The following is a description of a gene set: Any process that modulates the frequency, rate or extent of hydrolase activity, the catalysis of the hydrolysis of various bonds, e.g. C-O, C-N, C-C, phosphoric anhydride bonds, etc. Hydrolase is the systematic name for any enzyme of EC class 3. species: Mus musculus Mouse Gene Set: GOBP_REGULATION_OF_HYDROLASE_ACTIVITY, and this is the list of marker genes: Ric1, Tbc1d20, Pla2r1, Cast, Serpinb1b, Cav2, Cstb, Ralgapb, Chp1 (calcineurin-like EF hand protein 1), Mtmr9, Rgs10, Oas1f, Epha2, Rab3gap1, Ccdc159, Ecm1, Csta1, Cldn4, Timp3 (NCBI Gene Id 268324), Npnt, Nos1, Rdx, Oas1h, Csta2, Uri1, Spock1, Spink2, Sh3bp1, Furin, Rgs2, Serpinb13, Smcr8, Bmp2, Apoa5, Ect2, Scrib, Stfa2, Nf1, Gapdh-ps15, Cstdc6, Cstdc4, Rack1, Ifng, Apoc1, Cstdc3, Ptk2b, Amot, Pycard, Lrch1, Wnt4, Epha5, Srgap2, Calm1, Tmed10, Rasgrf1, Camk2a, Mtor, Psma3, Arfgef1, Cxcl13, Sgsm3, Rasgrp3, Rgp1, Nr1h2, Rhoa, Serpine1, Serpinb6e, Vav1 (vav 1 oncogene), Ubxn1, Ang4, Apoa1, Rangap1, Spink5, Tank, Rgs14 (regulator of G-protein signaling 14), Apoa2, Ppargc1b, Serpinb9c, Itgb1bp1, Fgfr3, Ppp1r17, Epha4, Spink6, Sod1, Serpinb9f, Apc2, Sipa1l1, Nos3, Hras, Serpinb1a, Mtss2, Akt1 (thymoma viral proto-oncogene 1), Pde3a, Ndel1 (nudE neurodevelopment protein 1 like 1), Ccpg1, Apoc3, Oas1a, Eppin, Vcp, Tmem106b (NCBI Gene Id 76086), Oas1e, Wnk1, Fermt2, Ccr7, Ager, Svbp, Mlst8, Arhgap35, Gpr137b, F2r, Arhgap11a, Timp1 (tissue inhibitor of metalloproteinase 1), Adap1, Dock8, Ang6, Arhgef19, Rasgrp2, Dab2ip, Rapgef1, Rgs16, Wdr41, Efna5, Met, Dennd1b (DENN domain containing 1B), Grhl3, Gapdh, S100a10, Ralbp1 (NCBI Gene Id 268968), Kalrn, Arhgef10, Usp6nl, Spink1, Arhgap44, Syde1, Gpr65, Asap3, Crkl, Serpinb9h, Cdk5rap3, Fetub, Wnt5a, Calm2, Spry1, Serpinb6d, Avpr1b, Rictor, Serpinb6b, Pnlip, Dock11, Pla2g5, Slc27a4, Nedd9, Scarb2, Arap1, Sort1, Stat3, Tbc1d2, Antxr1, Psenen, Grn, Calm3, Akt2 (thymoma viral proto-oncogene 2), Rabgap1, Prkcd, Angptl4, Csta3, Gpld1, Agrn, Dock9, Sgsm2, Tbc1d7, Prex1, Plxnb2 (NCBI Gene Id 73840), Rrp1b, Rgs6, Gpihbp1, Rgma, Timp2, Ngef, Rsu1, Chp2, Abr, Map4k4, Rab3gap2, Gnb5, Usp17le, Pkp4, Dvl2, Tax1bp3, Prelid1, Stmn1, Apoa4, Rgs1, Prom2, Dgki, Angptl3, Bbs4, Prss22, Ptx3, Ralgapa2, Snx9, Apoc2l, Lars1, Ntf3, Bcar3, Ajuba, Prtn3, Tmed2, Arhgap42 (NCBI Gene Id 71544), Mapre2, Gapdhrt2, Serpinb9g, Epm2a, Snx18, Mmut, Tiam1, Rhoc, Terf1 (telomeric repeat binding factor 1, NCBI Gene Id 21749), Rapgef6, Apcs, Psmb8, Itgb1, Mef2c, Nr1h3, Lrp1, Snca, Gapdhrt, Dock10, Pot1b, Ctsh, Wrn, Spock3, Cstdc5, Mkks, Plxnb1, Arl2, Ang2 (angiogenin, ribonuclease A family, member 2), Ccdc125, Arhgap6, Bcl6, Tbc1d10b, Mbp, Cd200, Coro1c, Rapgef2, Sirt1, Efna3, Tgm2, Rhbdf2, Plin5, Ttc8, Arhgap1, Lmf1, Evi5l, Terf2, Oas1c, Atp13a2, Zc3h15, Stfa1, Apoh (NCBI Gene Id 11818), Ripk3, Arhgef16, Pafah1b1, Rtn4r (reticulon 4 receptor), Ntrk2 (neurotrophic tyrosine kinase, receptor, type 2), Serpinb9e, Ccn1, Cst7, Ang5, Agtr1b, Reck, Ezh2, Rgs8, Rps3, Crb2, Ccl24, Serpinb9, Serpinb8 (NCBI Gene Id 20725), Ang, Rapgef3 (NCBI Gene Id 70104), Thy1, Plxnb3, Ncstn, Arhgef5, Ccl11, Pin1rt1, Prkg1, Vav3, Lims1, Ralgapa1, Serpine2, Nrdc, Bcr, Dvl3, Ntrk3, Fgfr2, Epha3 (Eph receptor A3), Pin1, Rcn3, Arhgap24, Gpsm1, Tbc1d30, Gzma, Cst3, Vav2, Pip5k1a, Evi5, Lepr, Aph1c, Dennd1a, Adcyap1, Tns3, Serpinb9b, Neil1, Sema4d, Odam, Tsc1, Rasip1, Rap1gap, Rhog, Serpinb1c, Cav1, Myo9b, Aph1a, Ccl19, Snx13, Oas3, Mex3b, Apoc2, Npm1, Net1, Arhgef7, Wnt11, Rap1a (NCBI Gene Id 99734), Oas1b, Cldn3, Tnf, Oas1d (2'-5' oligoadenylate synthetase 1D), Bves, Serpinb6a (serine (or cysteine) peptidase inhibitor, clade B, member 6a), Cblb, Wfdc6a, Sp7, Tmbim6, Gmip, Spry2, Ppp1r42, Gsk3b, Sfrp2, Foxj1, Rgs7, Cldn13, Rap1gds1, Ccl5, Stfa2l1, Oas1g, Bin1, Vsir, Itga6, Tmem225, C9orf72, Atp5if1, Pcna, Chn1, Angptl8, Park7, Ripor2, Agtr1a, F2rl1, Stfa3, Hmgb1, Rasgrp1, Dock7, Cd40, Ddrgk1, Serpinb6c, Aph1b, Efna1, Vtn (NCBI Gene Id 22370), Hpn, Rcc2, Rab11fip2, Serpinb9d, Rock1, Als2, Sh3bp4, Dffa, Ripor1 (RHO family interacting cell polarization regulator 1), Serpina5, Plaa, Tbc1d15, Tmem132c, Lyn, Fgd1, Plek, Crk, Ntrk1, Lrrk2, Psap, Ccl26, Ephb3, Bag4, Epha1